The following is a description of a gene set: Mouse Gene Set: GOCC_ENDOPEPTIDASE_COMPLEX A protein complex which is capable of endopeptidase activity. studied in species Mus musculus, and this is the list of marker genes: Thbd, Plaur, Psmd2, Psmd12, Capn2, Psmf1, Psma2, Cradd, Casp9, Capns1, Psmd1, Psma8, Ubqln4, Psma7, Immp2l, Psme4, Psmd6, Usp25, Psmb8, Psma6, Ecpas (Ecm29 proteasome adaptor and scaffold), Psmd11, Zfand2a, Psme1, Psma5, Psmd9, Usp14 (NCBI Gene Id 98113), Arxes2, Slc10a2, Sec11c (NCBI Gene Id 66286), Psmd4, Capn1, Spcs1, Psmc3, Casp2, Sec11a, Psmd14, Psmb2, Fcnb, Psmd7, Txnl1, Zfand2b, Psmd13, Cfh, Psmb1, Psme3, Psmc4, Psmd8 (proteasome (prosome, macropain) 26S subunit, non-ATPase, 8), Mbl2, Pigu, Plau, Ubqln1, Psma1, Psmb4, Ide, Uchl5, Elp2, Psmd3, Psmb9, Vcp, Spcs3, Rad23b, Psmb10, Psmd5, Psmc1, Arxes1, Psmc6, Capns2, Psmc2, Spcs2, Adrm1, Prickle1, Gpaa1, Pidd1, Psmc5, Pigs, Psme2, Psmb11, Pigt, Pmpcb, Hspb1, Dnajb2, Htra2, Psma4, Psmb5, Psmb6, Ubr1, Ube3a, Psmb7, Rad23a, Psmb3, Cfhr4, Immp1l, Pigk, Sem1, Adrm1b, Psmd10, Psma3